The following is a description of a gene set: TBK1-mediated autophagosome formation. Pathway ID: N01140. Pathway type: Reference. Pathway class: nt06464 Amyotrophic lateral sclerosis. Human Gene Set: KEGG_MEDICUS_REFERENCE_TBK1_MEDIATED_AUTOPHAGOSOME_FORMATION Pathway Definition from KEGG: TBK1 -> (SQSTM1,OPTN,NDP52,TAX1BP1,NBR1) == LC3-II studied in species Homo sapiens, and this is the list of marker genes: OPTN, NBR1, MAP1LC3B, MAP1LC3B2, MAP1LC3C, TAX1BP1, SQSTM1, TBK1, CALCOCO2 (calcium binding and coiled-coil domain 2), MAP1LC3A